Given this list of marker genes CYTH3, CEBPB (NCBI Gene Id 90277), IL1RN, TIMP1, SEMA4C, CCL4, SELPLG, NSMCE1, DUSP1, RND1, KRT16, TGM2, CHST11, CH25H, TUBB6, PGLYRP1, ITGB2, IER5, FPR2, GCH1, BYSL, PPP1R18, RASA3, INHBB, SYK, CD14, RNF122, SH2D5, SNTB2, NOPCHAP1, PADI4, S100A8, SLC2A3 (solute carrier family 2 member 3), ICAM1 (intercellular adhesion molecule 1), CD300LB, CXCL1, PLSCR1, ZFAND2A, SDC4, NOP58, POLR1B, NGF, MYO1G, EIF5A, TGFB1, BCL10, STAT5A, FST, PHLDA1, HAS3 (NCBI Gene Id 3038), GCNT2, KDM6B, NRROS, EGR1, FOSL1, SAA1, BCL2L11, MSN, MRTO4, PLBD1, CYP4F3, TM4SF1, HEATR1, RNF149, MEFV, SERPINE1, PTPN2 (protein tyrosine phosphatase non-receptor type 2), OSM, SLC6A14, IST1, TNFAIP2, CHI3L1, CD86, PILRA, LYN, NFKBIZ, RAB20, WDR36, JAK1, NFIL3, TNIP1, SEMA4D, SH3BP2, CALHM6, DDX39A, RNF19B, PRSS27, PDE4B, ZFP36, ARHGEF10L, MAFB, CXCL2 (C-X-C motif chemokine ligand 2), IL1B, S1PR3, CLEC4E, PTGES, CFL1, MAT2A, BIRC3, BAZ1A, STOM, TREM1, NOLC1, SLC7A5, GPRC5A, PPP4C, SLC15A3, CLIC4, IER3, GPSM3, C15orf48, MAFF, PGM2, TMEM185A (transmembrane protein 185A), OSMR, JUNB, MARCKSL1, PPP1R15B, ISY1, SELE, DUSP5, FLNA, SMIM3, MMP9, SLC3A2, SIRPB1, MYO1F, TSR1 (TSR1 ribosome maturation factor), PTX3, FOS, OLR1, NFKBID, ETS2, GEMIN5, NIP7, SPRY1, LIF, VASP, CXCL14, MPEG1, EPGN, NOP2, ENC1, SLC20A1, CORO1A (NCBI Gene Id 11151), HBEGF, PTPN6, ADAMTS9, BTG2, S100A9, IGF2BP2, CYTH4, STX11, CD44, NUAK2, CYTIP (NCBI Gene Id 9595), CEMIP2, FOSL2, PTPN12, LTB4R2, EIF4A1, CSRNP1, TIPARP, TWIST2, PGS1, SPI1, RAB31, FTSJ3, CLEC4D, NFKBIA, TNFAIP3, CLEC7A, UAP1, PIM1, CD300LF, CISH, USP43, NOCT, ETV6 (ETS variant transcription factor 6), RUVBL2, ADAMTS4, CSF3, HAS1, TPM3, CSF2RB, CHSY1, ACOD1, JDP2, EFHD2, CCDC86, MYBBP1A, GAR1, CSF3R, TLE3, RRP15, ARHGDIB, SLC29A2, ADAM8, IL6, here is a description of the gene set: Murine Cytomegalovirus (MCMV) infection leads to early activation of various immune cells, including B and T lymphocytes, before the actual initiation of antigen-specific adaptive immunity. This activation is partly driven by innate cytokines, including type I interferon (IFN), which are induced early after infection. The objective of this study was to address the role of type I IFN in shaping early/innate B and T cell responses to a primary acute viral infection. In order to decipher the specific impact of IFN-I on cell subsets, we performed a genome-wide expression analysis on WT splenic B and CD8 T lymphocytes isolated from C57BL/6 mixed bone marrow chimera mice. This study complements series GSE39555, which focused on early responses of NK cells and of the two subsets of conventional dendritic cells. Genes down-regulated in NK cells versus ITGAM+ dendritic cells. studied in species Homo sapiens Human Gene Set: GSE45365_NK_CELL_VS_CD11B_DC_DN